Given this list of marker genes BMP10, MIR17, CAMK2D, MEF2A, NOTCH1, AKAP6, TNFRSF1A, MTPN, MIR19B1, PI16, ARRB2, ARRB1, SLC9A1, ROCK1, ATP2B4 (NCBI Gene Id 54594), TRIM63, NR4A3, PARP1, LMNA, PAK1, PPARA, PARP2 (NCBI Gene Id 10038), RGS2, MIR21, MIR20A, ERRFI1, MSTN, SMAD4, MLIP, IGFBP5, CTDP1, EDN1, MIR199B, MIR145, PDE9A, ACACB, MIR1-1, FOXO1, MIR34B, HAND2 (heart and neural crest derivatives expressed 2), MIR214, P2RX4, GLRX3, IL6ST, APLNR, PPP3CA, TOMM70, YY1, RGS4, TNFRSF1B, G6PD, ADCY10, GATA5, CERS1, IGF1, SMAD3, PPARG, AGT, GSK3A, ROCK2, MIR25, MIR19A, CAV3, TWF1, TRPC3, FOXP1, STUB1, PRKCA, BECN1, ADRA1A, MIR208A, MYMK, MIR34C, LMCD1, MIR199A1, MIR133A1, here is a description of the gene set: Any process that modulates the frequency, rate or extent of muscle hypertrophy. species: Homo sapiens Human Gene Set: GOBP_REGULATION_OF_MUSCLE_HYPERTROPHY